Given this list of marker genes MTA3, DIP2B, TMOD4, RNF185, PIK3IP1, PPCDC, KCTD19, SLC35D2, IL18RAP, DAD1, NR1D2, CNTN2, CGA, CAMSAP2, CBLB, TNRC6C, PCMTD1, KDM7A, FXYD5, GABBR1, F2R, USE1, HCST, MGST2, SSBP2, PFDN5, NPFF, IFIT3 (interferon induced protein with tetratricopeptide repeats 3), PPP1R9B, KIF26B, TDRD9, PGPEP1, CRIM1, F2RL2, RTN4RL1, HM13, PDE7A, HSD17B11, MLXIP, IKBKB, LINC-PINT, SLC49A4, ZCCHC7 (NCBI Gene Id 84186), TMEM50A, ATF7, BRWD1, PDE2A, ZDHHC20, CLIC5, HIGD1A, PTTG1, EIF5, RHBDF2, CALHM6, DGUOK, ELOVL7, ERICH5 (glutamate rich 5), RFX1, CCDC107, SYNJ1, SLC20A1, CRY1, GNA11, ITGA1, INSR, UBN2, MYCBP2, MSS51, GGNBP2, PARP16, SLC38A9, KCNK16, EIF4E3, NEURL3, JAK1, GNL3, SGMS1, CYFIP1, ZMYND11, ANXA1, CCND2, ACVR2A (activin A receptor type 2A), NUDT16, CXCR6 (NCBI Gene Id 10663), EIF4G3, CDK8, INPP4B (NCBI Gene Id 8821), INSYN2B, SLC31A2, L3MBTL3, IFITM1 (interferon induced transmembrane protein 1), PAPPA2, CYP27A1, SOCS3, ZNF394, ZC3H18, PLCB2, TRIM2, ATP10D, MEOX1, TCP11L2, PKHD1 (NCBI Gene Id 5314), IL7R, FILIP1L, PPCS, TCTN3, FBXL17, SLC2A9, PELI1, ANKRD44, TMEM42, ASH1L, PITPNC1, MCCC1, KLRC1, LAPTM4A, PHETA1 (NCBI Gene Id 144717), VIPR1, ALAS2, ITPR2, XAF1, SOCS5, NEIL2 (nei like DNA glycosylase 2), SORL1, FCGRT, NCALD (neurocalcin delta), CX3CR1, TRMT61B, BTBD9, XYLT1, HSD17B8, EML5, SURF2, ATP8A1, SLCO3A1, SLC14A1, FRAT1, PPP1R12A, FHIP1B, SAMHD1, UNC79 (NCBI Gene Id 57578), EXOC6B, NIBAN1, PPM1J, TTC19, S100G, BTG1, ERCC5, PCID2, OGT, CDC37L1, here is a description of the gene set: The goal of the study was to identify the effects of TGF-beta on primary human macrophages maturated under different conditions. species: Homo sapiens Genes down-regulated in macrophages differentiated for 5 days in the presence of: IL4 versus IL4 and dexamethasone. Human Gene Set: GSE7568_IL4_VS_IL4_AND_DEXAMETHASONE_TREATED_MACROPHAGE_DN from publication Gratchev A, Kzhyshkowska J, Kannookadan S, Ochsenreiter M, Popova A, Yu X, Mamidi S, Stonehouse-Usselmann E, Muller-Molinet I, Gooi L, Goerdt S (PMID 18453574)